Given this list of marker genes CXCL3, MARCKSL1, KLF6, ZNF274 (NCBI Gene Id 51732), EXT1, LAMB3, IRF7, SAPCD1, SEC61G, ADRM1, PPA1, SLIRP, IFNB1, B2M, PIGA, BUD31, IL4I1, IL18BP, ARHGEF3, CMPK2, EIF2AK2, ATF3, LIN9, CD47, ARG1, IFIH1, TRAFD1, NECTIN2, JUN, LCN2, DUSP6 (NCBI Gene Id 1848), DNAAF10, CRELD2, TRIB3, TGM2, SLPI (NCBI Gene Id 6590), IFI35, TMEM40, JAK2, PPP1R15A, NMI, ICAM1, TNFRSF1B, FAM20C, RSAD2, CDK2AP2, RRP7A, ZNFX1, POLR2G, SAMHD1, CASP4, RASD1, UBA7, FOS (NCBI Gene Id 2353), ISG20, HLA-B, PSMB8, MAL, LARP1, UMPS, TNFSF10, LY6E, FGFBP1, CRCT1 (cysteine rich C-terminal 1), IFIT3, TAP1, C1R, AQP1, AXL, STAT1, IFIT2, ADAR (NCBI Gene Id 3427), TAP2, MYD88, VNN2, ISG15, CH25H, SAA1, HLA-C, PLAUR, HLA-G, TNF, SLFN12L, TRIM21, CXCL2, CXCL10, IRF5, CAPN5, KRAS, CCL13 (C-C motif chemokine ligand 13), G6PD, FARSA (phenylalanyl-tRNA synthetase subunit alpha), EPO, PLXND1, GPD2, MPEG1, HLA-E, EGR1, PLK2, CYBA, APOBEC1, BTK, HBEGF, GADD45G, GBP2, ERP44 (endoplasmic reticulum protein 44), ST3GAL1, GNA13, C3, GLRX, KLF7, NFKBIA, PSME1, PLAT, CCL5 (NCBI Gene Id 8147), TNK2, OSMR, NFKBIB, ACOD1, GADD45B, RASA4 (RAS p21 protein activator 4), PELI1, DNAJB11, PARM1, RNF19B, CXCL6, VNN1, RAB8A, DNAJC3, IRF1, CEBPD, CLIC4, CASP12, CTSS, AREG, GCH1, RABEPK, IRF9, UBA5, PDIA3, MANF, CYP3A7, SAC3D1, EIF6, SQSTM1, ATF4, LGALS3BP, HM13, CD14, LRRC59, USP18, BCL3, GTF2F1, MRPL45, GATA4, PHLDA1, GMPPB, CCRL2, IRGM, SLFN12, HSP90B1, IL1RN, PDIA6, PTGFRN, IFIT1B (interferon induced protein with tetratricopeptide repeats 1B), F11R, GK, TNFAIP2, SEC61A1, MX2, CEACAM21, CHI3L1, DDIT3 (DNA damage inducible transcript 3), CSF1, GBP4, NPC2, MT2A, ERO1B, CTSC, S100A10 (NCBI Gene Id 6281), PTGS2, PPIB, TFF2, ZFAND2A, GTPBP2, KRT20, IFITM3, MX1 (NCBI Gene Id 4599), GDPD3, CD74, LCAT, RPS6KA4, FAM3D, PTPN22, NOP58, CCND2, PSMB10, OSTC, WARS1, here is a description of the gene set: Human Gene Set: GSE18281_CORTICAL_VS_MEDULLARY_THYMOCYTE_UP Interaction of hematopoietic progenitors with the thymic stromal microenvironment induces them to proliferate, adopt the T cell fate, and asymmetrically diverge into multiple T lineages. Progenitors at various developmental stages are stratified among different regions of the thymus, implying that the corresponding microenvironments differ from one another, and provide unique sets of signals to progenitors migrating between them. The nature of these differences remains undefined. Here we use novel physical and computational approaches to characterize these stromal subregions, distinguishing gene expression in microdissected tissues from that of their lymphoid constituents. Using this approach, we comprehensively map gene expression in functionally distinct stromal microenvironments, and identify clusters of genes that define each region. Quite unexpectedly, we find that the central cortex lacks distinctive features of its own, and instead appears to function by sequestering unique microenvironments found at the cortical extremities, and modulating the relative proximity of progenitors moving between them. from publication Griffith AV, Fallahi M, Nakase H, Gosink M, Young B, Petrie HT (PMID 20064453) species: Homo sapiens Genes up-regulated in thymocytes: cortical versus medullary sources.